The following is a description of a gene set: Human Gene Set: HP_EXTERNAL_OPHTHALMOPLEGIA studied in species Homo sapiens Paralysis of the external ocular muscles. External ophthalmoplegia, and this is the list of marker genes: PHOX2A, ATXN3, TYMP, FA2H, MT-ATP8, LIG3, SDHD, KIF21A, MT-TQ, MT-ND4, DGUOK, SDHAF1, MT-CO2, TWNK, C1QBP, DNA2 (DNA replication helicase/nuclease 2), COL25A1, MT-TN, TUBB2B, NDUFAF2, SDHB, FRG1, LYRM7, SLC52A3, MT-TH, MT-TW, DNM2, MGME1, LRP12, TAMM41, MYF5, POLG, TOP3A, BIN1, ACADS, MT-CO1, MYF6, MFF, MTMR14, GIPC1, APTX, POLG2, OPA1, RNASEH1 (NCBI Gene Id 246243), MT-TT, STIM1, STUB1, SLC25A4, RRM2B, MT-TL2, NUTM2B-AS1 (NUTM2B antisense RNA 1), TK2, MT-TF, NSUN3, MT-ND5, MT-TS2, NFU1, TUBA1A, MTRFR, NOTCH2NLC, SALL4, SDHA, MT-TL1 (NCBI Gene Id 4567), VARS2, POLRMT, MT-TK, TUBB3, SLC19A3, ATG7, MTM1, RYR1, SCN4A, MT-CO3, HPDL, MT-ND1, RILPL1, MT-ND6